Given this list of marker genes TBC1D24, NCOA7, MEAK7, MIR132, OXR1, here is a description of the gene set: species: Homo sapiens Any process that stops, prevents or reduces the frequency, rate or extent of cellular response to oxidative stress. Human Gene Set: GOBP_NEGATIVE_REGULATION_OF_CELLULAR_RESPONSE_TO_OXIDATIVE_STRESS